The following is a description of a gene set: species: Mus musculus Any process that modulates the frequency, rate or extent of thyroid hormone generation. Mouse Gene Set: GOBP_REGULATION_OF_THYROID_HORMONE_GENERATION, and this is the list of marker genes: Duoxa2, Slco1c1, Gata3, Duoxa1, Pax8, Hpn, Ctns